The following is a description of a gene set: Mouse Gene Set: GOBP_MUSCLE_SYSTEM_PROCESS An organ system process carried out at the level of a muscle. Muscle tissue is composed of contractile cells or fibers. species: Mus musculus, and this is the list of marker genes: Nr4a3, Kcnip2, Ctnna3, Htr2a, Srf, Fxyd1, Cacna1g (calcium channel, voltage-dependent, T type, alpha 1G subunit), Pkp2, Chrnb4, Cflar (NCBI Gene Id 98571), Ptk2, Smad5, Tnnc1, Nmur1, Cav3, Lck, Htr1d, Nol3, Calca, Csrp3, Stac2, Chrne, Map2k6, Tbx2, Scnn1b, Tcap, Atp1a1, Ppp3ca, Myl3, Kcne4, P2ry1, Acta2, Dock5, Tmod3, Prkag3, Bin1, Scn11a, Casq1, Chrnd, Large1, Mybpc2 (NCBI Gene Id 233199), Adrb2, Kcnd2, Atp1b1, Oxt, Eno1b, Ep300, Kdm4a, Adrb1, Ryr2, Abcc8, 3425401B19Rik, Cttn, Gata6, Kcne5, Strit1, Mybpc1, Ace2, Kcnip1, Cald1, Stac, Drd2, Tmem38a, Oxtr, Arhgap42, Cacna1s, Smtn, Edn2, Slc25a4, G6pd2, Becn1, Sgcd, Pik3ca, Klk1b1, Sgca, Chrnb1, Kcne3, Ednra, Col6a1, Myom1, Tmem38b (NCBI Gene Id 72005), Drd1, Ptgs2, Lmod3, Tmod1, Adra2a, Tbce, Scn1b, Gtf2ird2, Trip10 (thyroid hormone receptor interactor 10), Myh7, Actn3, Cav1, Kcnn4, Tnni3, Igfbp5, Kcnj5, Rangrf, Grk2, Ang2, Tnni1, Camk2g, Dock4, Cdk9, Myog, Synm, Met, Itga2, Chrng, Kcnj8, Sirt1, Lep, Jarid2, Edn3, Rock2 (Rho-associated coiled-coil containing protein kinase 2), Adra2b, Myl2, Adk, Nmu, Kit, Tafazzin, Casq2, Ddx39b, Atp2a2, Myh13, Rgs4, Notch1, Ndufs6, Zfas1, Bmp2, Myoc (NCBI Gene Id 98481), Atp1a2, Ryr1, Ece1, Abcc9, Ghrl, Fkrp, Ccdc78, Dsc2, Prkca, Mtpn, Rock1, Pln, Gper1, Myh1, Bbs2, Rbm10 (NCBI Gene Id 260306), Mef2a, G6pdx, Cd38, Chrna1, Cacna1c, Sstr2, Acacb, Setd3, Oga, Glra1, Pde9a, Lmod1, Akap13, Pawr, Slc9a1, Ucn (urocortin), Ednrb, Lmcd1, Dlg1, Kbtbd13, Pin1, Gdnf, Cacna1h, Aldoa, Rgs2, Hey2, Rcsd1, Map2k3, Comp, P2rx1, Apbb2, Bmp10, Glrx3, Flt1 (FMS-like tyrosine kinase 1), Kcnn2, Aif1, Nr4a1, P2rx4, Snta1, Dmd, Grcc10, Foxo1, Kcnq1, Fdps, Kcna5, Myh7b, Pde4b, Map2k1, Myh3, Klf15, P2rx3, Htr7, Tnf, Pgam2, Mylpf, Zdhhc21, Hsbp1, Asb2, Tpcn2, Dsp, Hand2, Pak1, Jup, Cacna2d1, Tacr3, Neurog1, Ezh2 (NCBI Gene Id 14056), Igf1, Grip2, Akap9, Fkbp1a, Calm3, Klf4, Nfatc1, Rps6kb1, Ndufs4, Fkbp1b, Ppp1r13l, Nos3, Chaer1, Myh14, Mybpc3, Mymk, Ada, Trim63, Dbn1, Tnfrsf1a, Npy2r, Tnni2, Dmpk, Adra1b, Myh8, Gata5, Tnni3k, Pin1rt1, Cacnb1 (calcium channel, voltage-dependent, beta 1 subunit), Tnfrsf1b, Vps54, Mtor, Tacr1, Akap6, Cert1, Parp2, Rem1, Ryr3, Slc8a3, Pde4d, Mylk2, Apbb1, Ormdl3, Adra2c, Sorbs2, Ptger4, Sulf1, Scn2b, Mkks, Agt, Camk2d (calcium/calmodulin-dependent protein kinase II, delta), Pla2g6, Twf1, Scn4a, Pdlim5, Nfatc3, Actc1, Selenon, Myl4, Foxp1, Lmod2, Dag1, Kcnma1, Tpm4, Bmp4, Scn1a, Fbxo32, Npy1r (neuropeptide Y receptor Y1), Tpm2, Tpm3, Gaa, Prok2, Tiam1, Cmya5, Abat, Gucy1a1, Myh6, Hdac4, Hamp, Irag1, Eno1, Scn3b, Calm1 (calmodulin 1), Gdf1, Trpm4, Hamp2, Nos1, Chga, Pde5a, Myoz1, Smad7 (NCBI Gene Id 17131), Kcnd3, Myh11, Chrnb2, Fgf13, Inpp5f, Slc8a1, Nppc, Tnnc2, Calcrl, Tbx20, Ptafr, Atp8a2, Hsp90aa1, Smad3, Gpd1l, Prkg1, Kcne2, Foxo3, Nkx2-5, Stac3, Ddit3, Vegfb, Ptgs1, Clcn1, Trpv1, Atp2b4, Yy1, Shc1, Htr2b, Tpm1, Zfp418, Tnnt3, Sod1, Sco2, Stc1, Gja5 (NCBI Gene Id 70659), Rnf207, Atp2b1, Myh4, Cacna1d, Hrc, Tnnt2, Sri (sorcin), Pparg, Scn4b, Kcna1, Zc3h12a, Smad1, Adora2b, Myoz2, Atp1a3, Parp1, Tmod2, Trpa1, Cxcr4, Dyrk1a, Smad4, Anxa6, Dsg2, Pi16, Col14a1, Akap1, Errfi1, Srsf1, Npnt, Mlip, Tpm3-rs7, Bdkrb2, Adcy10, F2r, Mylk, Mef2c, Ptger3, Srl, Gatm, Agtr2, Mtmr4, Nr3c1, Tead1, Tifab, Camta2, Trim72, Gtf2ird1, Arg2, Cyba, Pak2, Nedd4l, Myh2, Actn2, Tmod4, Ank2, Agrn, Flna, Lmna, Gata4, Mstn, Nppb, Scn10a, Ghsr (NCBI Gene Id 208188), Stub1, Map2k4, Trpv4, Ttn, Edn1, Tbxa2r (NCBI Gene Id 21390), Sln, Tnnt1, Hcn4, Jsrp1, Smpd3, Ehd3 (EH-domain containing 3), Sphk1, Adra1a, Tomm70a, P2rx2, Uty, Myl6b, Myl6, Gsn, Prkd1, Ar, Trpc3, Ccn4, Scn5a, Rap1gds1, Tacr2 (NCBI Gene Id 21337), Adora1, Gsk3a, Ctdp1, Gsk3b, Myl1, Kcne1, Ppara, Psen2, Sumo1, Tshz3, Homer1, Myom2, Spx, Chrna3, Myocd, Cacng1, Acta1, Meis1, Sulf2, Tbx3, Cacnb2, Calm2, Nup155, Atp2a1, Rhoa, Chrm2, Myod1, Ccn2, Chrm3, Kcnh2, Nppa, Mir208b, Kcnj2